The following is a description of a gene set: Mouse Gene Set: GOBP_POSITIVE_REGULATION_OF_METALLOPEPTIDASE_ACTIVITY studied in species Mus musculus Any process that activates or increases the frequency, rate or extent of metallopeptidase activity., and this is the list of marker genes: Ddrgk1, Mbp, Antxr1, Stat3, Cldn3 (claudin 3), Cldn13, Cldn4